The following is a description of a gene set: An unresolved issue in immunology is the extent to which inflammatory effects are needed for robust T cell responses. In this study, mice were immunized by iv injection using either high toxicity lipopolysaccharide (LPS) or low toxicity monophosphoryl lipid A (MPL) as adjuvant. Six hours after iv immunization, whole spleens were harvested and gene expression was measured in unfractionated splenic populations of cells. The analysis indicated that the low toxicity adjuvanticity of MPL was associated with TLR4-mediated signaling that was biased to the TRIF branch of TLR4, while LPS generated balanced MyD88 and TRIF-associated outcomes. Genes up-regulated in spleens: LPS versus monophosphoryl lipid A. Human Gene Set: GSE7768_OVA_WITH_LPS_VS_OVA_WITH_MPL_IMMUNIZED_MOUSE_WHOLE_SPLEEN_6H_UP studied in species Homo sapiens from publication Mata-Haro V, Cekic C, Martin M, Chilton PM, Casella CR, Mitchell TC (PMID 17569868), and this is the list of marker genes: XRCC6, ZMYM2, TMX4, NEMP2, RDH13, CSRNP2, STAT6, SLC46A3, CEP44, GAN, PEPD, PHKA2, FANCG, FDXR, TMPO, QSER1, RNF169, IDH2 (isocitrate dehydrogenase (NADP(+)) 2), NAPB, TGFBRAP1, ADAM10, TRIM28, RNF166, GTF3C1, OSTM1, GPR146, SOCS6, GNE, TRMT2B, SUOX, NEK3, DNAJC3, TIGD2, DAGLA, STXBP5, TK1, RAD51C, CREG2, KDM2B, OXR1, NCAPD2, MAFB, RNF26, OXNAD1, SASH3, SLC30A5 (NCBI Gene Id 79021), TWNK, IPMK, FADS1, ZCCHC24, GTF3C2, FBXL17, HAVCR2, TPCN1, RETREG3, MRE11, MCM7, ZFTRAF1, REEP4, ACTR8, YTHDF3, PPCDC, ACAP3, HPS4, GPS2, ELMO2, SLC25A13, FAM107B, MPV17, TFDP2, PNPLA6, MRPS31, CHEK2, LPGAT1, CDCA5, IFFO1, TPCN2, TLCD1, NUF2, RBL2, ESCO2, CDS2, SIRT4, PPP2R5D, PHF2, ALMS1, GLIS3, UMPS, PDE4D, VPS13C, DTX4, FGD3, CDCA3, TRAPPC14, PMS2, NCAPH, RUNX3, CENPC, PAXIP1, ANKZF1, MRI1, THNSL1, ERCC4, FBLIM1, RWDD2A, THAP11, CENPM, HDAC6, DBF4, CRTAP, TBC1D9, IL6R, VDAC1, SPRED2, CCDC138, GPR157, EZH2, ELOVL5, POLG2, PNKP, INPP4A (NCBI Gene Id 3631), CARS2, MDM1, DAZAP1, BIN2, CROT, TMEM184C, DCTN5, DCTD, NEDD9, SMC3, LACTB, LMLN, DYRK1B, DPP7, CHTF18, CD151, NDFIP1, SNX14, PSMB3, PROKR1, MEX3B, NT5C2, SKA2P1, EXOC7, ZBTB44, NEU1, IKBIP, MMP19, ZBTB9, MUTYH, SLX1B, KANK3, SMAD3, SLC37A2, MYL12B, KNL1, PFAS, TMX2, MAP3K1, ASF1B, SLC5A3, C16orf54, HAUS1, H2AX, PYGB (glycogen phosphorylase B), MBLAC2 (NCBI Gene Id 153364), TGFBR1, RMI1, DAB2, LRRC8A